Given this list of marker genes DET1 (NCBI Gene Id 55070), CORO1C, KANSL1L, POLR2I, KCNN2, FEV, BCL6B, MLLT11, NOL4, CHD6, CDC42SE1, DES, BCL11B, CSRNP2, KDM2A, NOTCH3, SESN2, UPF2, CTR9, PTPN2, CDH2, MAP4K2, ERO1B, HSPB2, TEF, NUMBL, LYL1, NXPH3, PHLDA3, SOX2, CRY1, TM9SF3, RNF24, NKX2-1, THOC6, PIP4K2B, BHLHE41, ZNF687, SMARCD1, CAMKK1, HYAL2, IRF2BP1, CBLN1, GABARAP, DDX6, WNT1 (Wnt family member 1), UTP18, ING2, NR2F2, RBM4B, BMI1, CLDN11, TIPRL, ARFIP1, CACNA1D, AKT2, CDH3, BCL9L, SELENOF, PHOX2A, ARPC4 (actin related protein 2/3 complex subunit 4), CLSTN1, NFAT5, PDIK1L, ASIC1, DLX3, HSD11B2, RCOR2, MRPL49, MIR22HG, AGBL5, PITPNA, ERBB3, NTRK3, CAMK2G, CHAT, LDB1, SRR (serine racemase), THRA, WNT5A, GAS7, BCL6, RELB, CDH24, ANP32A, FBXL19-AS1, CHPF, CDK5R1, RANBP10, APLP2, GGN, KLF7, INA, ADAM10, DCAF1, DUSP15, TADA3, GRIN2A, PCGF2, FUT8, ASB7, MN1, TIGD4, MXD4, OSBP2, EN1, FGF12, FAM117B, UBE2O, PAK1, ONECUT1, CADM1, TMEM131L, SH3BP5, ATP2A2, TRIM28, SNX18, LINS1, PTHLH, ZFP91, PHF23, KLF16, TPM4, S1PR5, BDNF, PPP2R3A, WDR81, RTN3, TBCB, DNMT3A, SIX4, EFNB3, EGLN2, C2CD2L, ENAH, CTTNBP2NL, TBX2, HCN4, BCL3, PPRC1, KCNMA1, RTF1, AGO1, PHF21A, EFEMP2, RHOG, ZFP36, TIMELESS, FAF1, FBXO34 (F-box protein 34), FLVCR2, PAK4, OSBPL9, RAB2B, RAB26, HIPK1, SLC35F5, HS2ST1, ZNF768, SP3, GFRA1, CACNA1A, PTCH2, HAP1, ACLY, BAD, GRB2, CLPTM1, NCOA6, NLK, ETV5, KDF1, SYT9, LYRM1, ANKRD12, EVI5L, HOXB7, CREB1, KCNIP2, SIPA1, BAHD1, CRYAB (crystallin alpha B), PAX2, SNX2, NFE2L1 (NFE2 like bZIP transcription factor 1), ARHGEF19, FSTL5, GLI1, TBX3, UNC80, NDUFA4L2, ZNF414, MAP3K11, OAZ2, TCF12, HCFC1R1, PHF20, ACE, STARD13, CPSF7, SMG6, VAMP2, NPAS4, SPAG9, FBXO3, DCUN1D4, TAL1, GPR3, CADM2, PI4KB, EMSY, BCL7C, GGA1, TMEM256, PTPRJ (NCBI Gene Id 5795), HRH3, LASP1, ERC1, TSNAXIP1, KLF13, PER1 (NCBI Gene Id 5187), PPFIA2, SLC18A3, CGGBP1, INO80, NXPH4, FBXL19, SCARF2, PRMT1, SDHAF2, ADCK1, NTF4, FGF11, SLITRK5, GSC, CHKA, LOXL4, KCNB1, FGF5, MSANTD2, RELA, ERG, MECOM, FZD2, PIAS3, IGF2BP1, AJUBA, ADRB1, RAP1GDS1, ASCL2, here is a description of the gene set: Genes having at least one occurrence of the motif CCCCGCCCCN in the regions spanning 4 kb centered on their transcription starting sites. This matches the SP1 transcription factor binding site V$SP1_Q2_01 (v7.4 TRANSFAC). studied in species Homo sapiens Human Gene Set: SP1_Q2_01